The following is a description of a gene set: studied in species Homo sapiens The process in which a relatively unspecialized cell acquires the specialized features of a multi-ciliated epithelial cell. Human Gene Set: GOBP_MULTI_CILIATED_EPITHELIAL_CELL_DIFFERENTIATION, and this is the list of marker genes: CEP63, CCDC78, DEUP1, GMNC, TP73, IL13, FOXJ1, CEP152, TTC8, NFIB, CCNO, E2F4, PLK4, MCIDAS